Given this list of marker genes NXT2, NUTF2, NUP62, NUP35, NUP54, NXT1, here is a description of the gene set: The central substructure of the nuclear pore complex (NPC), through which nucleocytoplasmic transport of RNAs, proteins and small molecules occurs. The central transport channel is filled with FG-nucleoporins, which form a selective barrier and provide a series of binding sites for transporter proteins. Characterized S. cerevisiae FG-nucleoporins include Nup159p, Nup145Np, Nup116p, Nup100p, Nsp1p, Nup57p, Nup49p, Nup42p, Nup53p, Nup59p/Asm4p, Nup60p and Nup1. Characterized vertebrate FG-nucleoporins include Nup214, Nup98, Nup62, Nup54, Nup58/45, NLP1, and Nup153. Human Gene Set: GOCC_NUCLEAR_PORE_CENTRAL_TRANSPORT_CHANNEL studied in species Homo sapiens